The following is a description of a gene set: Sensory ataxia species: Homo sapiens Incoordination of movement caused by a deficit in the sensory nervous system. Sensory ataxia can be distinguished from cerebellar ataxia by asking the patient to close his or her eyes. Persons with cerebellar ataxia show only a minimal worsening of symptoms, whereas persons with sensory ataxia show a marked worsening of symptoms. Human Gene Set: HP_SENSORY_ATAXIA, and this is the list of marker genes: EGR2, GPI, NAGLU (N-acetyl-alpha-glucosaminidase), FLVCR1, PMP22, KPNA3, SH3TC2, UCHL1, TWNK, AARS1, DNAJC3, MPZ, POLG, PRX, PIEZO2, RNF170